The following is a description of a gene set: Transcripts stabilized by NO identified as up-regulated by NO in the presence of actinomycin D in IMR-90 and NIH 3T3 cells (fibroblast). studied in species Homo sapiens Human Gene Set: KUWANO_RNA_STABILIZED_BY_NO from publication Kuwano Y, Rabinovic A, Srikantan S, Gorospe M, Demple B (PMID 19289500) We previously observed that nitric oxide (NO) exposure increases the stability of mRNAs encoding heme oxygenase 1 (HO-1) and TIEG-1 in human and mouse fibroblasts. Here, we have used microarrays to look broadly for changes in mRNA stability in response to NO treatment. Using human IMR-90 and mouse NIH 3T3 fibroblasts treated with actinomycin D to block de novo transcription, microarray analysis suggested that the stability of the majority of mRNAs was unaffected. Among the mRNAs that were stabilized by NO treatment, seven transcripts were found in both IMR-90 and NIH 3T3 cells (CHIC2, GADD45B, HO-1, PTGS2, RGS2, TIEG, and ID3) and were chosen for further analysis. All seven mRNAs showed at least one hit of a signature motif for the stabilizing RNA-binding protein (RBP) HuR; accordingly, ribonucleoprotein immunoprecipitation analysis revealed that all seven mRNAs associated with HuR. In keeping with a functional role of HuR in the response to NO, a measurable fraction of HuR increased in the cytoplasm following NO treatment. However, among the seven transcripts, only HO-1 mRNA showed a robust increase in the level of its association with HuR following NO treatment. In turn, HO-1 mRNA and protein levels were significantly reduced when HuR levels were silenced in IMR-90 cells, and they were elevated when HuR was overexpressed. In sum, our results indicate that NO stabilizes mRNA subsets in fibroblasts, identify HuR as an RBP implicated in the NO response, reveal that HuR alone is insufficient for stabilizing several mRNAs by NO, and show that HO-1 induction by NO is regulated by HuR., and this is the list of marker genes: PTGS2, CHIC2, ID3, HMOX1, GADD45B, RGS2, KLF10